The following is a description of a gene set: species: Homo sapiens The vesicular release of glutamate from a presynapse, across a chemical synapse, the subsequent activation of glutamate receptors at the postsynapse of a target cell (neuron, muscle, or secretory cell) and the effects of this activation on the postsynaptic membrane potential and ionic composition of the postsynaptic cytosol. This process encompasses both spontaneous and evoked release of neurotransmitter and all parts of synaptic vesicle exocytosis. Evoked transmission starts with the arrival of an action potential at the presynapse. Human Gene Set: GOBP_SYNAPTIC_TRANSMISSION_GLUTAMATERGIC, and this is the list of marker genes: DRD3, CACNG2, GRIN3A, PSEN1, IQSEC2, NLGN1 (neuroligin 1), ABTB3 (NCBI Gene Id 440109), SLC38A2, KMO, GRIK5, ADORA2A, GRIN2D, ATP1A2 (NCBI Gene Id 93186), MEF2C, NLGN2, MIR142, GRID1, HCN1, SLC17A8, RNF167, HDAC6, GRIN1, GRIK3, CNIH3, GRIA4, CNIH2, NPS, GRM1, CDK5, NR3C1, OPHN1, LRRK2, GRM7, NAPB, ATAD1, DSCAM, NLGN3, GRIK2, TNR, HOMER1, TSHZ3, FXR1, CLSTN3, UNC13C, HTR2A, CACNG5, PLPPR4 (NCBI Gene Id 9890), GRIA1, GRM6, CCL2, TNF, DRD1, GRIK1, NRXN1 (neurexin 1), GRIN3B, UCN, RAB3GAP1, GRIN2A, CACNB4, ADORA1, CLCN3, DRD2, CCR2, GRID2, CDH8, STXBP1, DTNBP1, GRM4 (glutamate metabotropic receptor 4), KCNJ8 (potassium inwardly rectifying channel subfamily J member 8), DKK1, GRIN2B, UNC13B, TPRG1L, PTK2B, GRIN2C, CLN3, FRRS1L, DISC1, GRM8, EXT1, ABCC8, GRIA3, P2RX1, GRM3, VPS54, ALS2, GRIK4, SLC1A4, SERPINE2, MAPK8IP2, RELN, SHANK3, NF1, CACNG8, NPY2R (NCBI Gene Id 4887), GRM2, NTRK1, SYT1, CACNG4, UNC13A, SLC17A6, CACNG3, NAPA, GRM5, GRIA2, PRKN, CACNG7, SLC17A7